Given this list of marker genes SFTPC, RARRES2, SCGB1A1, MUC4, DRC3, IQCG, HIGD1B, DNAI2, SFTPB, SFTPA2, CLDN5, FABP6, DNAAF1, here is a description of the gene set: 14 candidate differentiation markers in lung adenocarcinoma cells, noncancerous lung cells and peripheral blood cells. Human Gene Set: NAKAMURA_LUNG_CANCER_DIFFERENTIATION_MARKERS To identify tumor markers and differentiation markers for lung adenocarcinoma (AdC), we analysed expression profiles of genes against three cases of type II alveolar epithelial cells, bronchiolar epithelial cells, and bronchial epithelial cells, respectively, and 10 cases of AdC cells isolated by laser capture microdissection. Hierarchical clustering analysis indicated that AdC cells and noncancerous lung epithelial cells are significantly different in their expression profiles, and that different sets of differentiation markers are expressed among alveolar, bronchiolar and bronchial epithelial cells. Nine genes were identified as being highly expressed in AdC cells, but not expressed in noncancerous lung epithelial cells. Sixteen genes were identified as differentiation markers for lung epithelial cells. Real-time RT-PCR analysis of 45 lung AdC cases further revealed that expression of four tumor markers in AdC cells was significantly higher than that in noncancerous lung cells and that expression of ten differentiation markers was retained in a considerable fraction of lung AdC cases. Five tumor markers and seven differentiation markers were not expressed in peripheral blood cells. Similarities and differences in expression profiles between normal epithelial cells from different lung respiratory compartments and AdC cells demonstrated in this study will be informative for the molecular diagnosis of lung AdC. from publication Nakamura N, Kobayashi K, Nakamoto M, Kohno T, Sasaki H, Matsuno Y, Yokota J (PMID 16491115) species: Homo sapiens